The following is a description of a gene set: Human Gene Set: GOCC_IGM_IMMUNOGLOBULIN_COMPLEX A protein complex composed of two identical immunoglobulin heavy chains of the IgM isotype and two identical immunoglobulin light chains, held together by disulfide bonds, and in its circulating form complexed with J chain in polymeric forms. An IgM immunoglobulin complex may be embedded in the plasma membrane or present in the extracellular space, in mucosal areas or other tissues, or circulating in the blood or lymph. studied in species Homo sapiens, and this is the list of marker genes: CD79B, IGKC, IGLC7 (immunoglobulin lambda constant 7), IGLC1, IGLC3, IGLC6, CD79A, IGKV3-20, JCHAIN, IGHM